Given this list of marker genes Astx4b (amplified spermatogenic transcripts X encoded 4B), Gm14932, Gm7781, Gm21616, Gm381, Gm17469, Gm14947, Rps12-ps11, Rps12-ps16, Astx2, Gm14985, Rps12-ps20, Astx1a, Btk, Gm14979, Gm7857, 4921511C20Rik, Rps12-ps23, Nap1l3, Mir7093, Gm10344, Armcx3, Armcx4, Tnmd, Rps12-ps18, Gm5403, Drp2, Rps12-ps22, Gm15018, Gm24522, Gm16421, Gm7823 (predicted gene 7823), Gm26029, Gm7820, Gm14987, Gla, Armcx6, 4930558G05Rik, Gm23277, Rps12-ps12, Cstf2, Srpx2, Cldn34c4, Gm17412, Rps12-ps21, Nox1, Gm14977, Gm7058, Gm14971, Astx4c, Rpl36a, Astx1b, Gm14975, Trmt2b (TRM2 tRNA methyltransferase 2B), Tspan6, Pcdh19, Gm23586, Rps12-ps17, Gm25170, Zmat1, Cldn34c3, 4930570D08Rik, Srsx, Gm7821, Vmn2r121, Rps12-ps14, Armcx7-ps, Armcx2, Nxf2, Gm14942, B230119M05Rik, Rps12-ps6, Gm7222, Dmtf1l, Gm14981, Astx6, Timm8a1, Xkrx, Armcx1, Gm14940, Gm14945, Cldn34c6, Tmem35a, Gm4916, Gm14957 (NCBI Gene Id 626086), Mdm4-ps (transformed mouse 3T3 cell double minute 4, pseudogene), Gm23768, Gm14943, Cldn34c5, Cldn34c2, Gm16410, Gm22139, Rps12-ps13, Gm23124, Gm4994, Gm17467, Gm17522, Gm17267, Astx3, Rps12-ps15, Astx4d, Gm14986, Cenpi, Sytl4, Astx1c, Gm7746, Gm7841, Gm7790, Gm17584 (predicted gene, 17584), Diaph2, Astx5, Taf7l, Gm17521, Gm5648, Gm14950, Gm17577, Cldn34c1, Mir3112, Gm17693, Gm25412, Arl13a, Gm14976, Gm7855, Gm4992, Gm14980, Gm14984, Hnrnph2, Gm26406, here is a description of the gene set: studied in species Mus musculus Mouse Gene Set: chrXE3